Given this list of marker genes AR, MAMLD1, CYP17A1, MTM1, WT1, here is a description of the gene set: Blind vagina Human Gene Set: HP_BLIND_VAGINA The vagina ends in a blind pouch or sac rather than being connected to the internal genitalia. studied in species Homo sapiens